Given this list of marker genes TDG, ATP1A2, CAPN3, SLC6A4, SLC34A2, ATP1A1, AMELX, SCN8A, PDXK, here is a description of the gene set: Human Gene Set: GOMF_SODIUM_ION_BINDING species: Homo sapiens Binding to a sodium ion (Na+).